The following is a description of a gene set: Human Gene Set: GOBP_DENDRITIC_CELL_MIGRATION The movement of a dendritic cell within or between different tissues and organs of the body. species: Homo sapiens, and this is the list of marker genes: CCR1, CCR6, SLAMF1, CXCR2, CCL19, PIK3CG, LGALS9, CCR7, CCL21, SPI1, IL12A, EXT1, NLRP12, CCR5, ASB2, EPS8, TNFSF18, TRPM2, CCR2 (C-C motif chemokine receptor 2), HMGB1, CDC42, CXCR4, TRPM4, ALOX5, GPR183, ARHGEF5 (NCBI Gene Id 7984), SLAMF8, DOCK8, C1QBP, CALR, GAS6, CCL5, CXCR1